The following is a description of a gene set: species: Homo sapiens The process whose specific outcome is the progression of the skeletal myofibril over time, from its formation to the mature structure. A skeletal myofibril is a myofibril specific to skeletal muscle cells. Human Gene Set: GOBP_SKELETAL_MYOFIBRIL_ASSEMBLY, and this is the list of marker genes: MYH11, PLEC, ACTA1, LMOD3, TTN, CFLAR, TCAP, PROX1, ACTC1